The following is a description of a gene set: The process of assisting in the covalent and noncovalent assembly of single chain polypeptides or multisubunit complexes into the correct tertiary structure. species: Homo sapiens Human Gene Set: GOBP_PROTEIN_FOLDING, and this is the list of marker genes: CCT3, CLPX, CCT6B, TTC4, TSC1 (NCBI Gene Id 7248), PPIB, PDIA3, HSPD1, RANBP2, KHSRP (KH-type splicing regulatory protein), SNRNP70, CCT8, FKBP9, BAG2, DNAJB6, METTL21A, B2M, PDCL3, DNLZ, MPDU1, TELO2, ALG12, HYOU1, PDILT, CSNK2A1, CLU, PPIL3, HSPA1B, HSP90B1, TBCE, NGLY1, PPWD1, HSP90AB3P, PFDN5, BAG4, HSPA8, FKBP8 (NCBI Gene Id 23770), DNAJA4, CCT4, NPPB, ERO1B (NCBI Gene Id 56605), PDCD5, GRN, PFDN6, QSOX1, SACS, HSPA2, HSPH1, PPIAL4F, PTGES3L, CDC123, RIC8A, DNAJA3, PPIL2, POFUT2, DNAJC10, DFFA (DNA fragmentation factor subunit alpha), PPIE, DNAJC4 (NCBI Gene Id 93087), PPIAL4C, PDIA2, ANP32E, TXNDC5, TBCD, PDIA6, CHORDC1, HSPA9, CCT5, NPPC, PPIAL4A, HSPA13, PPIH, CRYAB, TOR2A, RP2, PPIAL4E, ERP27, TBCEL, WDR83OS, P4HB, DNAJB2, PPID (peptidylprolyl isomerase D), FKBP1B, FKBP1A, HYPK, SELENOF, NUDC, BAG1, DNAJB14, DNAJB3 (NCBI Gene Id 414061), QSOX2, CDC37L1, PEX19, CHCHD4, DNAJB4, APCS, ERO1A, SDHAF4, PFDN4, PDIA5, CDC37, TRAP1, PDIA4, TTC1, VAPA, ZMYND10, GFER, FKBP6, DNAJB8, HSP90AB4P, DNAJC5, NFYC, NUDCD3, DNAJC7, TCP1, HSPB6, HSPA4, P3H1, APLF, AHSA1, SDF2, PDRG1 (NCBI Gene Id 96818), PPIL1, FKBP4, CCT2, VBP1, NPPA, PTGES3, PFDN1, HSP90B2P, AHSA2P, GAK, ARL2, DNAJB5, MKKS (NCBI Gene Id 8195), DNAJC3, DNAJA1, RIC8B (RIC8 guanine nucleotide exchange factor B), CLGN, DNAJB1, TBCB, HSP90AA2P, FUT10, ERP44, TBCA, ELP6, HSPA1L, SH3GLB1, TOR1A, PPIAL4H, PDCL2, DNAJA2, PPIF, HSP90AB1, BAG5, LTBP4, CWC27, DNAJC1, CD74, ERP29, DNAJB13, HSP90AA4P, UNC45A, LMAN1, DNAJC2, HSPA7, SDF2L1, DNAJB7, CCT8L1P (NCBI Gene Id 402629), FKBP2, PPIC, BAG3, MOGS, HSPBP1, FKBP10, CCDC47, UNC45B, SIL1, TAPBP, ENGASE, HSPA1A, CRTAP, DNAJC25, GRPEL2, HSPB2, HSPA6, CCT8L2, LYRM7, HSP90AA1, TOR1B, NKTR, CALR, DNAJC21, HSPA4L, PPIAL4G, UGGT1, TBCC, HSP90AB2P, WIPF1, HSPA5, CANX, DNAJC24, RIC3, ZPR1, NUDCD2, HSPE1, FKBP11, UMOD, PPIG, CALR3, ATF6, HSP90AA5P, AIFM1, DNAJC18, PPIAL4D, PPIA, GRPEL1, AHSP, LMAN2L, PFDN2, RUVBL2, MESD, DNAJC19, CCT7, ENTPD5, HSPB1, CCT6A, ST13, HSPA14, DNAJB12, CRYAA, DNAJB11, FKBP5